Given this list of marker genes ADSL, RNU4-2, SH3PXD2B, PEX16, METTL23, SLC25A12, PPP1R21, TAF1, MCTP2, CYP27B1, ERF, SETD1B, FIG4, PEX13, PEX14, NEUROG1, VDR, PEX12, SYNE1, TWIST1, MAN1B1, ASPM, PTCH1, UFC1, RPS23, UBE3A, OCRL, EHMT1 (euchromatic histone lysine methyltransferase 1), PEX1, CYP2R1, KIF11, TUBB3, UBE3B, PEX2, INPPL1, RALGAPA1, PEX6, PEX10, EZH2, SNRPN, FGFR2, DPM1, OCA2, TMEM70 (transmembrane protein 70), ZIC1, SLC35A1, SLC34A3, PEX19, HK1, PEX11B, PIGA, PEX3, AMER1, WDR73, PEX26, OTUD6B, SATB2, IL11RA, PEX5, PPIB, MAN2B1 (mannosidase alpha class 2B member 1), here is a description of the gene set: species: Homo sapiens Flat occiput Reduced convexity of the occiput (posterior part of skull). Human Gene Set: HP_FLAT_OCCIPUT